Given this list of marker genes IL6, CXCL11, NFKB1, TBK1, IFIH1 (NCBI Gene Id 64135), CCL2, IL18, TNF, IL1B, TLR8, MAVS, CGAS, CXCL10, CSF2, RIGI, CXCL9, STING1, TLR3, IRF3, TLR7, here is a description of the gene set: Human Gene Set: WP_LUNG_PATHOLOGY_OF_COVID19 Lung pathology of COVID-19 studied in species Homo sapiens